Given this list of marker genes NLRC4, NLRP1, NFKB1, PYCARD, HSP90AB1, RELA, MEFV, fliC, BCL2L1, hly, AIM2, SUGT1, APP, TXNIP, prgJ, BCL2, CASP1, P2RX7, NLRP3, fljB, PANX1, NFKB2, PSTPIP1, HMOX1, TXN, here is a description of the gene set: species: Homo sapiens part of: Nucleotide-binding domain, leucine rich repeat containing receptor (NLR) signaling pathways Reactome Pathway: Inflammasomes In contrast to NOD1/2 some NLRPs function as large macromolecular complexes called 'Inflammasomes'. These multiprotein platforms control activation of the cysteinyl aspartate protease caspase-1 and thereby the subsequent cleavage of pro-interleukin 1B (pro-IL1B) into the active proinflammatory cytokine IL1B. Activation of caspase-1 is essential for production of IL1B and IL18, which respectively bind and activate the IL1 receptor (IL1R) and IL18 receptor (IL18R) complexes. IL1R and IL18R activate NFkappaB and other signaling cascades.<br><br>As the activation of inflammasomes leads to caspase-1 activation, inflammasomes can be considered an upstream step of the IL1R and IL18R signaling cascades, linking intracellular pathogen sensing to immune response pathways mediated by Toll-Like Receptors (TLRs). Monocytes and macrophages do not express pro-IL1B until stimulated, typically by TLRs. The resulting pro-IL1B is not converted to IL1B unless a second stimulus activates an inflammasome. This requirement for two distinct stimuli allows tight regulation of IL1B/IL18 production, necessary because excessive IL-1B production is associated with numerous inflammatory diseases such as gout and rheumatoid arthritis.<br><br>There are at least four subtypes of the inflammasome, characterized by the NLRP. In addition the protein AIM2 can form an inflammasome. All activate caspase-1. NLRP1 (NALP1), NLRP3 (Cryopyrin, NALP3), IPAF (CARD12, NLRC4) and AIM2 inflammasomes all have clear physiological roles in vivo. NLRP2, NLRP6, NLRP7, NLRP10 and NLRP12 have been demonstrated to modulate caspase-1 activity in vitro but the significance of this is unclear.<br><br>NLRP3 and AIM2 bind the protein 'apoptosis-associated speck-like protein containing a CARD' (ASC, also called PYCARD), via a PYD-PYD domain interaction. This in turn recruits procaspase-1 through a CARD-CARD interaction. NLRP1 and IPAF contain CARD domains and can bind procaspase-1 directly, though both are stimulated by ASC. Oligomerization of NLRPs is believed to bring procaspases into close proximity, leading to 'induced proximity' auto-activation. This leads to formation of the active caspase tetramer. NLRPs are generally considered to be cytoplasmic proteins, but there is evidence for cytoplasmic-nuclear shuttling of the family member CIITA and tissue/cell dependent NALP1 expression in the nucleus of neurons and lymphocytes; the significance of this remains unclear.